Given this list of marker genes ATP7A, NGFR, SHH, FGF10, NOTCH1, NAGLU, TP63, BCL2, KRT25, EXT1, INTU, KRT17, GLI2 (NCBI Gene Id 50806), CTNNB1, KRT28, TMEM79, SMO (smoothened, frizzled class receptor), FOXE1, TGM3, PLA2G10, FLG2, KRT27, KRT71, PLOD3, FGF7, SOSTDC1, FGFR2, DLX3, KLF4, FOXQ1, SNAI1, GORAB, KLK14, DSC1, FST, TGFB2, WNT10A, IGFBP5, here is a description of the gene set: The process in which the anatomical structures of the epidermis are generated and organized. The epidermis is the outer epithelial layer of an animal, it may be a single layer that produces an extracellular material (e.g. the cuticle of arthropods) or a complex stratified squamous epithelium, as in the case of many vertebrate species. species: Homo sapiens Human Gene Set: GOBP_EPIDERMIS_MORPHOGENESIS